The following is a description of a gene set: species: Mus musculus Heme signaling Mouse Gene Set: REACTOME_HEME_SIGNALING, and this is the list of marker genes: Slc46a1, Pgrmc2, Apoa1, Bach1, Ly96, Hbb-bs (hemoglobin, beta adult s chain), Clec1b, Hba-a1, Xpo1, Tlr4, Hbb-bt, Apob, Mafk